The following is a description of a gene set: from publication Wierenga AT, Vellenga E, Schuringa JJ (PMID 18779318) studied in species Homo sapiens Genes down-regulated in CD34+ cells by intermediate activity levels of STAT5A; predominant long-term growth and self-renewal phenotype. The level of transcription factor activity critically regulates cell fate decisions, such as hematopoietic stem cell (HSC) self-renewal and differentiation. We introduced STAT5A transcriptional activity into human HSCs/progenitor cells in a dose-dependent manner by overexpression of a tamoxifen-inducible STAT5A(1*6)-estrogen receptor fusion protein. Induction of STAT5A activity in CD34(+) cells resulted in impaired myelopoiesis and induction of erythropoiesis, which was most pronounced at the highest STAT5A transactivation levels. In contrast, intermediate STAT5A activity levels resulted in the most pronounced proliferative advantage of CD34(+) cells. This coincided with increased cobblestone area-forming cell and long-term-culture-initiating cell frequencies, which were predominantly elevated at intermediate STAT5A activity levels but not at high STAT5A levels. Self-renewal of progenitors was addressed by serial replating of CFU, and only progenitors containing intermediate STAT5A activity levels contained self-renewal capacity. By extensive gene expression profiling we could identify gene expression patterns of STAT5 target genes that predominantly associated with a self-renewal and long-term expansion phenotype versus those that identified a predominant differentiation phenotype. Human Gene Set: WIERENGA_STAT5A_TARGETS_DN, and this is the list of marker genes: TMEM44, TPM2 (NCBI Gene Id 7169), DAAM1, MCEMP1, USP20, LGALS12, PRTFDC1, PCYOX1L, TMC8, PPM1F, ANGPTL6, C5, GP9, GCSAML, ACRBP, ITGB1BP2, MSRB3, TCEAL1, LGALSL (galectin like), PLEKHO2, GP6, CCDC9B, IFI16 (interferon gamma inducible protein 16), TREML1, PLXDC2, CAMK1, C3orf52, GJA4, SAMD14, MANSC1, ALOX12, PPIF, PLCG2, JAM3, NDUFAF3, SLC22A23, ANGPT1, SMAD6, WASF3 (NCBI Gene Id 10810), EFHC2, LINC01341, TUBGCP4 (NCBI Gene Id 27229), GNG11, TTC27, BANK1, MEIS1, H4C2, SBDSP1, MTMR11, ARMT1, SALL2, DCLRE1A, CD47, ITPKB, CCND1 (NCBI Gene Id 893), CLCN4, SLC9A9, ARHGEF3, WFDC1, DOK3, CD93, CHST12, LOXL3, MYEOV, PECAM1, ITGB7, LYZ, ETS1, ROCK2, CAPN11, RGS18, PROS1, GP1BA, ARMCX5, NAT8B, MS4A3, COTL1, NINJ2, CGRRF1, EFNB2, PDLIM1, CARD19, RASGRP3, MGLL, DENND2C, STX11, PSTPIP2, RUFY1, ZNF185, LY6G6D, FCER1G, ADRA2A, IRS2, LILRA2, PRKD2, CD14, ARHGAP21, LDLRAD4, NAP1L3, SLC24A3, C6orf226, CXCR4, PDIA5, PLCB2, DLK1, DEPTOR, SH3PXD2A (SH3 and PX domains 2A), TMEM163 (NCBI Gene Id 81615), PLEK, FAM30A, SLC12A2, XYLT2, VASH1, PF4V1, CLDN5, SUSD3, CTSG, LCN2, NFIB, PTGIR, ITGB5, CTDSPL, ACOT11, SPX, CAVIN2 (caveolae associated protein 2), CTIF, MRPS14, FCER1A, PIP4P2, GPX1, PROSER2, GP1BB, VWF, FAR2, IL7, EAF2, CLCN2, GFOD1, SPNS3, PADI4, PSRC1, EMILIN1, OGFRL1, IL17RA, DEPDC1, CD96, UBASH3B, FERMT3, TPM4, GAPT, IRF8, TNNC2, TRIM8, SCPEP1, GUCY1B1, SLC9A1, SELP, TLN1, SLC37A1, ARAP3, SERPINF1, ZYX, RBPMS2, HGD (NCBI Gene Id 727722), CD9, ADORA2A, TTK, KLHDC1, CD84 (NCBI Gene Id 8832), MPL, BAMBI (BMP and activin membrane bound inhibitor), ASAP2, ILK, NOTCH1, DNAAF3 (dynein axonemal assembly factor 3), CRACR2B, LST1, TSPAN32, LHFPL2, CORO1A, MYLK, ACTN1 (NCBI Gene Id 87), EPHX2, ZFPM1 (NCBI Gene Id 161884), HEXIM2, FCN1, SMIM8, PBX1, MARCHF5, BATF, STX1A, BIN1, SH3BGRL2